The following is a description of a gene set: studied in species Homo sapiens In this study, transcriptomic and clinical data were downloaded from the TCGA database, and ferroptosis-related genes were obtained from the FerrDb database. Through correlation analysis, Cox analysis, and the LASSO algorithm for constructing a prognostic model, we found that ferroptosis-related lncRNA-based gene signatures (FLncSig) had a strong prognostic predicting ability in the LUAD patients. Gene Ontology (GO) and Kyoto Encyclopedia of Genes and Genomes (KEGG) enrichments reconfirmed that ferroptosis is related to receptor-ligand activity, enzyme inhibitor activity, and the IL-17 signaling pathway. Next, tumor mutation burden (TMB), tumor immune dysfunction and exclusion (TIDE) algorithms, and pRRophetic were used to predict immunotherapy response and chemotherapy sensitivity. The IMvigor210 cohort was also used to validate the prognostic model. In the tumor microenvironment, Type_II_IFN_Response and HLA were found to be a group of low-risk pathways, while MHC_class_I was a group of high-risk pathways. Patients in the high-risk subgroup had lower TIDE scores. Exclusion, MDSC, CAF, and TAMM2 were significantly and positively correlated with risk scores. In addition, we found 15 potential therapeutic drugs for LUAD. Finally, differential analysis of stemness index based on mRNA expression (mRNAsi) indicated that mRNAsi was correlated with gender, primary tumor (T), distant metastasis (M), and the tumor, node, and metastasis (TNM) stage in LUAD patients. from publication Dong J, Tao T, Yu J, Shan H, Liu Z, Zheng G, Li Z, Situ W, Zhu X, Li Z (PMID 38043920) A 30-lncRNA signature (FLncSig) associated with ferroptosis and overall survival in lung adenocarcinoma (LUAD), derived via univariate Cox, LASSO, and multivariate Cox regression analyses on TCGA data. Human Gene Set: DONG_LUNG_ADENOCARCINOMA_FERROPTOSIS_LNCRNA, and this is the list of marker genes: LINC01312, LINC00623, LINC01638, LINC00862, LINC01800, LINC01585, LINC02880, MIR646HG, LINC01150, LINC01711, FAM66C, LINC02448, LINC03065, SEMA6A-AS2